Given this list of marker genes ZMYND8, PVR (NCBI Gene Id 5817), TMEM143, FGF1, TDRD1, PRKN, PLCB4, FAT1, ATP6V1C1, PMP2, PCDHB6, BBC3, PTCH2, CIDEC, TLL2, ARHGEF7, SLC22A2, N4BP2L1, SOX10, CNNM2, CEACAM21, EPPIN, SHANK2, CEP164, ERBB4, NFIA, SEZ6L, GABRB3 (gamma-aminobutyric acid type A receptor subunit beta3), GPATCH2L, IL9R, RHPN1-AS1, PSG2, IFNA4, KCNJ5, PDE6A, MYO1B, LIM2, SBNO2, DENND2A, KLF12, DRG2, STARD13, CORO2B (coronin 2B), NXPH3, ADCY8, GATA2, RAPGEF1, NR4A1, MYO7A (myosin VIIA), RPH3AL, NPHP4, KSR1, BCORL1, INSL5, BASP1, PSG6, RAI1, PIK3R5, HGH1, HOXC8, CA6, IQCA1, OPRK1, THSD1, NLRP1, EDA, NNAT, CACNB4, PKD1, ARHGAP33 (NCBI Gene Id 93092), XIST, BCO1, ONECUT1, CNPY4, CDH6, COL2A1, here is a description of the gene set: Up-regulated genes in the signature set for lymph node metastasis in head and neck squamous cell carcinoma (HNSCC). Human Gene Set: ODONNELL_METASTASIS_UP studied in species Homo sapiens Metastasis via the lymphatics is a major risk factor in squamous cell carcinoma of the oral cavity (OSCC). We sought to determine whether the presence of metastasis in the regional lymph node could be predicted by a gene expression signature of the primary tumor. A total of 18 OSCCs were characterized for gene expression by hybridizing RNA to Affymetrix U133A gene chips. Genes with differential expression were identified using a permutation technique and verified by quantitative RT-PCR and immunohistochemistry. A predictive rule was built using a support vector machine, and the accuracy of the rule was evaluated using crossvalidation on the original data set and prediction of an independent set of four patients. Metastatic primary tumors could be differentiated from nonmetastatic primary tumors by a signature gene set of genes. This signature gene set correctly predicted the four independent patients as well as associating five lymph node metastases from the original patient set with the metastatic primary tumor group. We concluded that lymph node metastasis could be predicted by gene expression profiles of primary oral cavity squamous cell carcinomas. The presence of a gene expression signature for lymph node metastasis indicates that clinical testing to assess risk for lymph node metastasis should be possible. from publication O'Donnell RK, Kupferman M, Wei SJ, Singhal S, Weber R, O'Malley B, Cheng Y, Putt M, Feldman M, Ziober B, Muschel RJ (PMID 15558013)